The following is a description of a gene set: Human Gene Set: GOMF_CARBOHYDRATE_TRANSMEMBRANE_TRANSPORTER_ACTIVITY Enables the transfer of carbohydrate from one side of a membrane to the other. studied in species Homo sapiens, and this is the list of marker genes: SLC5A10, SLC2A7, SLC23A2, SLC45A4, SLC5A9, SLC2A3, SLC5A2, SLC2A8 (solute carrier family 2 member 8), SLC2A11, SLC5A3, SLC45A1, AQP10, SLC50A1, SLC5A4, PPBP, SLC2A12, SLC5A1, AQP2, SLC17A5, AQP3, AQP7, AQP9, SLC5A11, SLC2A2, AQP1, SLC2A14, TMEM144, SLC2A6, SLC2A5, SLC2A10, SLC45A2, SLC2A1 (NCBI Gene Id 6513), AQP7B, AQP11, SLC2A4, SLC23A1, SLC45A3, SLC2A9 (NCBI Gene Id 56606)